The following is a description of a gene set: studied in species Homo sapiens ERBB2 extracellular domain (ECD) mutants harbor missense mutations that lead to substitutions of amino acid residues in the heterodimerization arm contact surface, involved in formation of ERBB2 heterodimers. The functionally studied ERBB2 ECD mutants, ERBB2 G309A, ERBB2 G309E and ERBB2 S310F seem to preferntially heterodimerize with EGFR. Heterodimerization of ERBB2 G309E involves formation of disulfide bonds. ERBB2 S310F shows stronger activation of downstream signaling than ERBB2 G309A and ERBB2 G309E, and is hyperphosphorylated on tyrosine residues in the C-tail, while the C-tail phosphorylation of ERBB2 G309A and ERBB2 G309E is comparable to the wild type ERBB2.<br> RAS signaling and PLCgamma1 signaling are activated dowsntream of all three ERBB2 ECD mutants, ERBB2 G309A, ERBB2 G309E and ERBB2 S310F, as evidenced by activating phosphorylation on ERKs (MAPK1 and MAPK3) and PLCG1, respectively. ERBB2 G309E and ERBB2 S310F also activate PI3K/AKT signaling, demonstrated by activating phosphorylation of AKT1. Activation of PI3K/AKT signaling downstream of ERBB2 G309A has not been tested. Signaling downstream of ERBB2 S310Y has been poorly characterized and it is annotated as a candidate. Many regulators of cell migration show increased phosphorylation in cells expressing ERBB2 G309E and ERBB2 S310F.<br>Comapred with the wild type ERBB2, ERBB2 G309E, ERBB2 S310F and ERBB2 S310Y are more sensitive to the ERBB2-directed therapeutic antibody trastuzumab (herceptin) and to tyrosine kinase inhibitors lapatinib, neratinib and afatinib. ERBB2 G309A was also responsive to trastuzumab, lapatinib and neratinib. part of: Signaling by ERBB2 in Cancer Reactome Pathway: Signaling by ERBB2 ECD mutants, and this is the list of marker genes: KRAS, GRB2, PIK3R1, NRAS, EGF, ERBIN, HSP90AA1, EGFR, HRAS, CDC37, SHC1, PLCG1, PIK3CA, GAB1, SOS1, ERBB2